Given this list of marker genes TYROBP, LILRB2, SNRPG, STMN4, PSME2, ETV6, TBX6, TSPAN9, IFIT2, APOBEC3A, EIF4E, STRN4, LIMD2, TXNDC15, OAS3, ZFP36L2, MAL2, GP1BA, PDHA1, CDKN1C, SDK2, FGF6, LMO2, RFPL3, CSDC2, AKIP1, CCT5, FLVCR2, HSH2D, IFI6, LSM6 (LSM6 homolog, U6 small nuclear RNA and mRNA degradation associated), CCL25, FGR, HNRNPU, GNAS, MPEG1, MT1M, PHF2, CEACAM7, SLC23A3, JDP2, GDA, HERC5, ZSCAN10, IL2RG, NCOA1 (nuclear receptor coactivator 1), PSME1, YEATS2, CALCOCO1, CHMP5, LENG8, PLSCR1, TMEM106A (transmembrane protein 106A), CTBP2, PCOLCE, LZTS1, ERH, A2ML1 (alpha-2-macroglobulin like 1), KCNH2, SIDT2, MT1X, OAS1, AQP1, ZBTB20, THRB, TAF6, PTPN2, PRR13, SRI (NCBI Gene Id 6717), IFITM2, MX1, SIGLEC7, APOBEC3B, OASL, RWDD3, SNRPE, IFIT5, SEC61B, UHMK1, PIM3, MRPL10, TENT5A, UBE2D3, TYR, SLC26A5, CX3CR1, DOCK10, MT1G, HERC6, SERPING1, DHX58, CHD5, PTP4A1, ARHGAP1, GLRX, STAB2, KMT5C, IFNA17, MS4A7, SCFD1, LARS2, SDC3, TRIP12, DDA1, RTP4, CEP57, FERMT3, LAP3, CDX4, ZCCHC8, COX5A, DSE, PARG, LRRC4C (NCBI Gene Id 57689), SP110, SAMD9L, HJURP, IFNA10, APAF1, TNFAIP2, MAN2B2, MAD2L1BP, PSMA4, GMPR, NBN, PYCR2, KLRA1P, CDC45, RIGI, MARCKS, ZCCHC2, BLVRA, MCM2, RGS14, FERMT2, ATP6V1G1, CMPK2, P2RY10, TUBA1A, PLAC8, MARK4, IFI44, MKRN3, NCBP3, MX2, H3C3, IER5, TNK2, SERPINB10, ITGAM (NCBI Gene Id 3684), TDRD7 (tudor domain containing 7), FOXN3, H3C1, NPHP1, OR1Q1, DRAP1, KRTAP4-11, NMI, COP1, KLHL28, BEX4, SPATS2L, HCFC1, ISG15, SLC25A22, PINLYP, JUND, ABR, IL17A, CD86, H3-4, CCL8 (NCBI Gene Id 96488), GPR137C, MNT (NCBI Gene Id 4335), RHO, H3C11, DSTN, SOWAHA, NF1, GTF3C6, OR4K17, LRP5L, ALYREF, TRHDE, PSMD10, LBX2-AS1, SPRY4, LARP1, SSR1, TNFSF10, KPTN, NUCKS1, USP18, IFITM1, CHMP2B, CCR5, WDR49, NOTCH3, RNF220, IL1RN, IFIT1, ALAS1, KCNJ10, BCL2L14, HAND1, EIF2AK2, NMNAT3, SLITRK2, CTH, VRK2, ADIPOR2, TAS2R5, HYPK, KRTCAP2, DNAJC2, SF3B1, FOXO3 (forkhead box O3), DUSP11, PLEK, TAP1, CHST2, SRPX, ZNF24, CD177, HNRNPA3P1, HMOX1, ANXA2, SNX5, FCGR3A, H3C8, TMPRSS11E, DEFB105A, GNPTG, ZMIZ1 (NCBI Gene Id 57178), TAGLN3, CIAO2A, CISD2, RABGAP1L, AP3S1, MAP3K5, PLAG1, SOX9, MDH1, SERPINA1, SASH1, IFI44L, CYP3A43, HSPH1, RMI1, TNFSF13B, IRF9, ASB4 (ankyrin repeat and SOCS box containing 4), HNRNPC, PARP12, PTP4A2, LRRC3B, CEBPB, CHST15, PSMB9, NRBF2, ISG20, FPR2, H3-3B, CDK12, RFWD3, H3C12, STARD13, NFKBIA, HS3ST4, SARDH, PMM2, NRBP2, BET1L, IFITM3, PECAM1, APEX2 (apurinic/apyrimidinic endodeoxyribonuclease 2), SAMD9 (sterile alpha motif domain containing 9), LGALS3BP, SRC, NOTCH2, NHLH2, ZHX3, APOD, PYHIN1, TRMT112, SCO2 (NCBI Gene Id 9997), HSBP1 (NCBI Gene Id 3281), CD74, LY6E, H3C7, HEXIM1 (HEXIM P-TEFb complex subunit 1), H2AZ2, GSTK1, EBNA1BP2, OAS2, RAB11FIP4, IFI30, ATG3, ZC3H4, NEK7, SMAD6, MTF1, DNAJA1, NCAPG2, SYNGR3 (synaptogyrin 3), KLF14, DAZAP2, PDCD10, CD53, SCAMP2, HMGN2, ATP6V0E1, PBX3-DT, TRIM22, DYNLT1, GBP5, SBF2, JUNB, CACNA2D2, WFDC3, RABL2B, TRIM8, STAT6, IGSF3, S100A11, CSF1R, IFIT3, DNAJC5, IFI27, TRIM21, MBTPS1, RBX1, MTREX, RRM2, SMARCC2, SHISA5, SNAI2, EGR4, HCN3 (hyperpolarization activated cyclic nucleotide gated potassium channel 3), NISCH, PALM2AKAP2, PSMA6, CREG1, CEBPA-DT, PPAN, XAF1, ABCB1, PARP9, EIF4A1, MAFB, SAT1, H3-3A, CAV2, TFDP3, MT2A, CST4 (NCBI Gene Id 1472), here is a description of the gene set: Human Gene Set: SCHERER_PBMC_YF_VAX_AGE_18_40YO_4_TO_7DY_UP Genes up-regulated in peripheral blood mononuclear cell (4 to 7)d vs 0d in adults (18-40) after exposure to YF-Vax, time point 4 to 7D species: Homo sapiens Gene expression in human peripheral blood mononuclear cells was systematically evaluated following smallpox and yellow fever vaccination, and naturally occurring upper respiratory infection (URI). All three infections were characterized by the induction of many interferon stimulated genes, as well as enhanced expression of genes involved in proteolysis and antigen presentation. Vaccinia infection was also characterized by a distinct expression signature composed of up-regulation of monocyte response genes, with repression of genes expressed by B and T-cells. In contrast, the yellow fever host response was characterized by a suppression of ribosomal and translation factors, distinguishing this infection from vaccinia and URI. No significant URI-specific signature was observed, perhaps reflecting greater heterogeneity in the study population and etiological agents. Taken together, these data suggest that specific host gene expression signatures may be identified that distinguish one or a small number of virus agents. from publication Scherer CA, Magness CL, Steiger KV, Poitinger ND, Caputo CM, Miner DG, Winokur PL, Klinzman D, McKee J, Pilar C, Ward PA, Gillham MH, Haulman NJ, Stapleton JT, Iadonato SP (PMID 17651872)